The following is a description of a gene set: species: Homo sapiens Human Gene Set: KEGG_MEDICUS_VARIANT_EGF_OVEREXPRESSION_TO_RAS_ERK_SIGNALING_PATHWAY Pathway Definition from KEGG: EGF* -> EGFR -> GRB2 -> SOS -> RAS -> RAF -> MEK -> ERK EGF-overexpression to RAS-ERK signaling pathway. Pathway ID: N00276. Pathway type: Variant. Pathway class: nt06260 Colorectal cancer., and this is the list of marker genes: SOS2, KRAS, SOS1, EGF, EGFR, MAPK3, RAF1, ARAF, MAPK1 (mitogen-activated protein kinase 1), BRAF, MAP2K2, HRAS, MAP2K1, NRAS, GRB2